The following is a description of a gene set: studied in species Mus musculus Any process that modulates the frequency, rate or extent of macrophage migration. Mouse Gene Set: GOBP_REGULATION_OF_MACROPHAGE_MIGRATION, and this is the list of marker genes: Cd200r1, Trpv4, Slamf1, Mtus1, Mmp14, Ptprj, C5ar1, Mst1, Trem1, Ccr2, P2ry12, Rtn4, Mif, Ptk2, Emilin1, Csf1, Cd9, Cmklr1, Tnfsf18, Ccl5, Cnn2, Slamf8, Mapk1, Cd200, Ptk2b, Mstn, Cx3cr1, Mapk3, C3ar1, Cyp19a1, Rarres2, Ccl21a, Akirin1, Trem2, Hc, Bcr, Mdk, Csf1r, Ccr7 (C-C motif chemokine receptor 7), Cxcl17, Ccl2, Stap1, P2rx4, Abr, Cd81, Il34, Cx3cl1, Thbs1, Mmp28